The following is a description of a gene set: Human Gene Set: GOCC_CYTOPLASMIC_SIDE_OF_ROUGH_ENDOPLASMIC_RETICULUM_MEMBRANE studied in species Homo sapiens The side (leaflet) of the rough endoplasmic reticulum membrane that faces the cytoplasm., and this is the list of marker genes: GNRH1, RPS28, RPS26, EPM2A, RPL27, RPS29, ALG5